The following is a description of a gene set: from publication Chen Y, Wang X (PMID 31504780) Genes predicted to be targets of miRBase v22 microRNA mmu_miR_7663_3p in miRDB v6.0 with MirTarget v4 prediction scores > 80 (high confidence targets). species: Mus musculus Mouse Gene Set: MIR_7663_3P, and this is the list of marker genes: Nr3c1, Esp34, Gpr141, Map2, Fbxw8, Ptprb, Lhx9, Jam2, Brwd3, Ube2v2, Bmp4, 4931429L15Rik, Naip6, Tmprss15, Rbm27, Abt1, Npsr1, Lrrc17, Meis1, Iffo2, Rasal2, Prkn, Sar1b, Prkca, Mapk1, Atp11a, Elavl1, Bpifa2, St8sia1, Dnah17, Neurog2, Steap4, Meis2, Ube2d3, Zfp811, Seh1l, Glul, Mospd2, Hpse2, Cadps, Zfp266, Lrig3, Thnsl1, Bcor, Acly, Mllt1, Psg25, Fut9, Erc2, Ankrd13a, Lrrc8c, Mobp, Ssr1 (NCBI Gene Id 67100), Tfdp2